The following is a description of a gene set: Any process that activates or increases the frequency, rate or extent of the IRE1-mediated unfolded protein response. Human Gene Set: GOBP_POSITIVE_REGULATION_OF_IRE1_MEDIATED_UNFOLDED_PROTEIN_RESPONSE species: Homo sapiens, and this is the list of marker genes: BAK1, BAX, BBC3, DAB2IP, BCL2L11, AGR2, PTPN1, TMEM33